Given this list of marker genes RAB6A, SP3, HADHB, ARFGEF1, SDHA, TMBIM6, XPO7, SEM1, SART3, VGLL4 (NCBI Gene Id 9686), ARPC5, VPS26A, CS, SERP1, DCTN2, SMARCD2, AP3S1, TMED2, RTN4, SEC24C, RAC1, KXD1, ATG12, RAB1A, BCAP31, AHCYL1, PPP1R7, NONO (non-POU domain containing octamer binding), DYNC1I2, PAPSS1, ATP6AP1, ATXN2, GPAA1, GLB1, CLTA, SPCS2 (signal peptidase complex subunit 2), MDH1, CLSTN1, COPS5, SNRNP200, CTDNEP1, TCEA1, WBP2, MYL11, PRKAR1A, ARF3 (NCBI Gene Id 377), IDH3G, LYPLA1, KDELR1, STARD7, MRPL9, KHDRBS1 (NCBI Gene Id 10657), ABR, TIAL1, MTDH, F8A1, FBXW11, PHF3, PPP2R1A, AFG3L2, FAM120A, ENSA, MTA1, CANX, SUMO1, METAP1, TRAPPC3, here is a description of the gene set: studied in species Homo sapiens Neighborhood of RAB6A Neighborhood of RAB6A RAB6A, member RAS oncogene family in the MORF expression compendium Human Gene Set: MORF_RAB6A